Given this list of marker genes SLC45A2, PDIA6, YWHAZ (NCBI Gene Id 83242), MMP14, TFRC, ATP6V1G2, SEC22B, ATP1B3, ATP6V1B2, TPCN2, STOM, TMED10, RAN, HSP90AA1, GNA13, SERPINF1, ANXA11, SND1, ATP7A, NCSTN, HSP90B1, ABCB6, RAB2A, ANKRD27, MLANA, SYTL1, BSG, SLC1A4, ANXA2P2, CD63, YWHAE, CTSD, RAC1, DCT, SGSM2, LAMP1, DTNBP1, DNAJC5, RAB5A, SDCBP, STX3, GANAB, TPP1, YWHAB, HSP90AB1, TYR, HSPA5, SLC1A5, RAB32, P4HB, FASN, MFSD12, SLC2A1, SLC24A5, APOE, HSPA8, PDIA3, RAB7A, ANXA6, MYH11, ATP6V0A1, AHCY, ATP1A1, BACE2, TMEM33, CTNS, MYO7A, SYTL2, CANX, CAPG, HPS4, PMEL (premelanosome protein), PRDX1, RAB5C, ITGB1, CLTC, RAB29, GGH, CCT4, MYRIP, ANXA2, SYPL1, PPIB, RAB35, TYRP1 (tyrosinase related protein 1), ERP29, NAP1L1, PDIA4, RAB9A, RAB27B, ITGB3, FLOT1, RAB5B, CNP, RAB17 (RAB17, member RAS oncogene family), SLC3A2, RPN1, CALU, TRPV2, MYO5A, GPNMB, RAB1A, OCA2, RAB38, MREG (NCBI Gene Id 55686), CTSB, SYNGR1, RAB27A, GCHFR, PDCD6IP, TH, GPR143, here is a description of the gene set: Human Gene Set: GOCC_PIGMENT_GRANULE A small, subcellular membrane-bounded vesicle containing pigment and/or pigment precursor molecules. Pigment granule biogenesis is poorly understood, as pigment granules are derived from multiple sources including the endoplasmic reticulum, coated vesicles, lysosomes, and endosomes. studied in species Homo sapiens